The following is a description of a gene set: species: Mus musculus Any process that stops, prevents or reduces the frequency, rate or extent of intrinsic apoptotic signaling pathway in response to DNA damage. Mouse Gene Set: GOBP_NEGATIVE_REGULATION_OF_INTRINSIC_APOPTOTIC_SIGNALING_PATHWAY_IN_RESPONSE_TO_DNA_DAMAGE, and this is the list of marker genes: Bid, Kdm1a, Ell3, Cd44, Sirt1, Cd74, Trim32, Marchf7, Triap1, Ccar2, Cxcl12 (NCBI Gene Id 20315), Usp47, Ackr3, Tmem161a, Bcl2l12, Bcl2l1, Atad5, Zfp385a, Muc1, Snai1, Clu, Cdkn2d, Mif, Ddias, Snai2, Tpt1